Given this list of marker genes Arhgap25, Timd4, Trem2, Xkr8, Itga2, Clcn3, Plcg2, Alox15 (NCBI Gene Id 11687), Siglece, Cdc42, Clec7a, Megf10, Aif1, Ager, Xkr7, Pparg, Havcr1, Ighg2b, Abca1, Fcgr3, Fcgr1, Becn1, Timd2, Itgb2, Elmo1, Ighg1, Dppa1 (developmental pluripotency associated 1), Rab31, Bin2, Gata2, Sh3bp1, Lbp, Thbs1, Sirpa, Timd6, Arhgap12, Appl2, Nckap1l, Itgam, F2rl1, Marco, C3, Msr1, Cd300a, Xkr4, Ano6, Timd5, Gsn, Gulp1 (GULP, engulfment adaptor PTB domain containing 1), Xkr6, Stap1, Fcgr2b, Cd36, Myh9, Fcer1g, Clcn2, Abca7, Rac1, Treml4, Adgrb1, here is a description of the gene set: The internalization of bacteria, immune complexes and other particulate matter or of an apoptotic cell by phagocytosis, including the membrane and cytoskeletal processes required, which involves one of three mechanisms: zippering of pseudopods around a target via repeated receptor-ligand interactions, sinking of the target directly into plasma membrane of the phagocytosing cell, or induced uptake via an enhanced membrane ruffling of the phagocytosing cell similar to macropinocytosis. Mouse Gene Set: GOBP_PHAGOCYTOSIS_ENGULFMENT species: Mus musculus